The following is a description of a gene set: Any process that modulates the frequency, rate or extent of vasculogenesis. studied in species Homo sapiens Human Gene Set: GOBP_REGULATION_OF_VASCULOGENESIS, and this is the list of marker genes: EMP2, CEACAM1, ASB4, TMEM100, CD34, RRAS, RTN4, RIN2, HEY1, KDR (kinase insert domain receptor), RAPGEF2, ADM, HEY2, RAP1A, HIF1AN, RAMP2